Given this list of marker genes ITM2C, CD96, B4GALT6, BAALC (BAALC binder of MAP3K1 and KLF4), PXMP2, TMEM106C, PAK6, PROM1, ENDOD1, PRG3, IFITM2, ALDH4A1, TUBG1, HNRNPD, TPX2, ASB9, HLA-DPA1, NPR3, PITPNC1, HLA-DRA, HLA-DRB6, HGF, GALC, KIAA0930, MTHFD1, DDX60, PIP5K1B, PLXNC1, ABCB1, MAD2L1, PBX2, HLA-DMA, POLE, GYPA, CORO2A, GNG7, GYPC, SEPTIN9, HLA-DRB1, CENPX, LY86, MCM10, FAAH, FOXM1, IL1R2, MCM2, KIFC1, CSGALNACT1, UBE2G2, MAN1A1, AGTPBP1, HMMR, POU4F1, GPA33, KIF4A, RHD, HNRNPA3, ACAT1, GAMT, IFITM1, SERPINF1, CHAF1A (NCBI Gene Id 107985297), GNB5 (G protein subunit beta 5), CD34, NUP210, TYMS, DUT, KCNIP2, CYFIP2, MECR, SORL1, OGG1, KIF23, MAP2K3, ATP8A1, MICAL1, CD48, RANBP1, TRAK2, CCNF, TRIB2 (NCBI Gene Id 28951), DAAM1, HMGN3 (high mobility group nucleosomal binding domain 3), PLAGL1, IGFBP7, RSAD2, PMAIP1, RGS10, EPS8, PALM2AKAP2, XPA, INSL3, CIITA, PTTG1, TRH, CD38, CDKN2C, MCM4, CD200, NINJ2, RHOBTB3, MKI67, CCNB1 (NCBI Gene Id 891, cyclin B1), GPX7, BLVRB, UBE2C, EXO1, CHEK1, RPA1, SRD5A1 (steroid 5 alpha-reductase 1), PLXND1, SERPINI1, ANK1, HADH, EGFL7, DHFR, SYNGR1 (NCBI Gene Id 9145), HDAC9, USP13, SLC1A4, POLD1, WDR62, CDC6, RPS6KA2, DLGAP5, BIRC5, GET3, CKS1B, MDFIC, TNFRSF14, REPS2, NXT2, VEGFA, HPCAL1, BANK1, MLLT3, INPP4B, EVL, PRR5L, STOM, SPARC, CCNB2, ADISSP, POLE2, ITM2A, TK1, IDH2, RBM3, NCAPH, RAD23B, MREG, CENPM, CDC25C, ARL2, STK32B, CDKN3, ACAA2, TESC, CD69, GSN, SERPINB6, MN1, HAAO, CRHBP, HOMER2, STAP1, ATF6B, KIF2C (kinesin family member 2C), TSPAN13, SIDT1, TFDP1, KYNU, DHRS3, OTULINL, RRM2, ABCG2, S100B, WASF1, IL2RG, CDC20, NNT (NCBI Gene Id 23530), ITGA9 (integrin subunit alpha 9), FKBP1B, DTYMK, SHCBP1, CCNA2, here is a description of the gene set: Genes down-regulated in acute myeloid leukemia (AML) with respect to cellular localization of NPM1: cytoplasmic vs. nucleolar. from publication Alcalay M, Tiacci E, Bergomas R, Bigerna B, Venturini E, Minardi SP, Meani N, Diverio D, Bernard L, Tizzoni L, Volorio S, Luzi L, Colombo E, Lo Coco F, Mecucci C, Falini B, Pelicci PG (PMID 15831697) studied in species Homo sapiens Human Gene Set: ALCALAY_AML_BY_NPM1_LOCALIZATION_DN Approximately one third of acute myeloid leukemias (AMLs) are characterized by aberrant cytoplasmic localization of nucleophosmin (NPMc+ AML), consequent to mutations in the NPM putative nucleolar localization signal. These events are mutually exclusive with the major AML-associated chromosomal rearrangements, and are frequently associated with normal karyotype, FLT3 mutations, and multilineage involvement. We report the gene expression profiles of 78 de novo AMLs (72 with normal karyotype; 6 without major chromosomal abnormalities) that were characterized for the subcellular localization and mutation status of NPM. Unsupervised clustering clearly separated NPMc+ from NPMc- AMLs, regardless of the presence of FLT3 mutations or non-major chromosomal rearrangements, supporting the concept that NPMc+ AML represents a distinct entity. The molecular signature of NPMc+ AML includes up-regulation of several genes putatively involved in the maintenance of a stem-cell phenotype, suggesting that NPMc+ AML may derive from a multipotent hematopoietic progenitor.